The following is a description of a gene set: studied in species Homo sapiens Human Gene Set: TRAVAGLINI_LUNG_PERICYTE_CELL from publication Travaglini KJ, Nabhan AN, Penland L, Sinha R, Gillich A, Sit RV, Chang S, Conley SD, Mori Y, Seita J, Berry GJ, Shrager JB, Metzger RJ, Kuo CS, Neff N, Weissman IL, Quake SR, Krasnow MA (PMID 33208946), and this is the list of marker genes: CPM, SYNM, COL4A1, B2M, ITM2C, LAMB1, NRCAM, AGTR1, SLC35B3, CDH6, PLCB1, ITGA1, CSPG4, TXNIP, DPYSL2, GJA4 (NCBI Gene Id 2701), TRIB2, SEMA6D, HSPA2, SPRY4, TESC, ARHGEF17, GPC4, ADAMTSL3, APOLD1, GUCY1A2, CHST2, PLXDC1, AFAP1L2, TBX5, ARHGDIB, ADGRF5, PERP, PCDH18, PLCE1, PCDH1, STOM, CADM1, NDRG1, FAM162B, MEST, GMFG, P2RY14, SORT1, LPL, CLMN, INSC (NCBI Gene Id 387755), WLS, PEAR1, MYO10, APOE, MATN3, PRDM1, FARP1, PAG1, ANKRD44, ETV5, COX4I2, FOXF1, LRCOL1, MYO1B, PDGFRB, CCDC68, NCK2, PTN, PREX2, GPX3, DUSP4, NID1, KCNK3 (NCBI Gene Id 3777), IGFBP2, MCAM, PON2, SLC12A2, GJC1, TRPC6, SEMA5A, GABRB2, TNFRSF21, TACC1, NOTCH3, NDUFA4L2, RFTN1, TMEM204, RPS6KA2, COL4A2, F2R, ADGRG6, CDH19, EFHD2, UXS1, EFEMP1, VSNL1, HIGD1B, IMPA2, CHN1, EGFL6, OBSCN, KCNK17, PDZD2, CCDC102B, TTYH2, ADGRD1, RGN, DGKG, SGIP1, FOXF2, EZR, RGS5, ADCY3, ESAM, PDE8B, EBF1, LAMC3